The following is a description of a gene set: Human Gene Set: GOMF_AMINOACYL_TRNA_DEACYLASE_ACTIVITY species: Homo sapiens The hydrolysis of an incorrectly aminoacylated tRNA., and this is the list of marker genes: AARS2, TARS2, VARS1, LARS1, LARS2, DTD1, PRORSD1P, IARS1, IARS2, DTD2, AARS1, VARS2, AARSD1